The following is a description of a gene set: species: Homo sapiens Any process that activates or increases the frequency, rate or extent of endothelial cell development. Human Gene Set: GOBP_POSITIVE_REGULATION_OF_ENDOTHELIAL_CELL_DEVELOPMENT, and this is the list of marker genes: PROC, ADD1, CDH5, S1PR2, F11R, CLDN5